Given this list of marker genes HDAC2, PPP1R9B, SLC6A4, OXT, NHLH2, DMRTA1 (DMRT like family A1), NCOA1, HEXB, here is a description of the gene set: The specific behavior of a male organism that is associated with reproduction. Human Gene Set: GOBP_MALE_MATING_BEHAVIOR studied in species Homo sapiens